Given this list of marker genes SCNN1B, CLDN18, AHCYL1, AQP8, CFTR, CSF2, EDNRB, SLC26A6, SLC5A1, PKP1, ITPR1, EDN1, AQP1, here is a description of the gene set: studied in species Homo sapiens Human Gene Set: GOBP_EPITHELIAL_FLUID_TRANSPORT The directed movement of fluid across epithelia.